Given this list of marker genes Srsf6, Eif4enif1, Rbmxl1, Mir466l, Traf2, Nbas, Vegfa, Pcbp4, Axin2, Noct, Mtor, Rbm47, Rbm10, Dazl, E2f1, Mettl16 (NCBI Gene Id 76970), Srsf4, Tent5b, Cirbp, Tent5c, Igf2bp3, Zc3h14, Boll, Acin1, Ptbp1, Igf2bp2, Elavl4, Akr1c6, Zar1, Mettl14, Hnrnpd, Meioc, Csde1, Hnrnpu, Traf3ip2, Srsf1, Paip1, Qki, Gdnf, Srsf7, Rbm20, Dicer1, Ybx2 (Y box protein 2), Tirap, Ptbp3, Pkp3, Vip, Zfp36, Elavl1 (ELAV like RNA binding protein 1), Mapkapk2, Tent5a, Myd88, Sfswap (NCBI Gene Id 68937), Rbm46, Taf15, Tent5d, Rbm42, Il17a, Rbm38, Slc11a1, Tent4a, Nrde2, Npm1, Pkp1, Fus (NCBI Gene Id 338527), Hnrnpa2b1, Rnps1, Tent4b, Dhx9, Ybx1, A1cf, Hnf4aos, Hnrnpk, Celf4, Igf2bp1, Larp4b, Tob1, Bag4, Dyrk1a, Fxr1, Dnd1, Tnf, Dhx34, Sap18, Arid5a, Tardbp, Pabpc1, Hnrnpc, Traf5, Rbm24, Nicol1, Hnrnpab, C1qbp, Apobec1, Srsf10, Fam76b, Upf3a, Angel2, Hnrnpa0, U2af2, Syncrip, Ikbke, Thrap3, Sap18b, Srsf9 (NCBI Gene Id 66453), Secisbp2, Larp1, here is a description of the gene set: Mouse Gene Set: GOBP_NEGATIVE_REGULATION_OF_MRNA_METABOLIC_PROCESS studied in species Mus musculus Any process that stops, prevents or reduces the frequency, rate or extent of mRNA metabolic process.